Given this list of marker genes NPC1, RNF41, LZTS1, SCFD1, VPS13C (NCBI Gene Id 57581), HMOX1, QSOX1, USP30, FBXL4, NRBP2, PPTC7, UBQLN4, CLEC16A, NUPR1, AKT1, LYPLA1, TP53, TMEM39A, BECN1, EHMT2, LRRK2, RUBCN, MTOR, POLDIP2, SEC22B, TSPO, SMCR8, FEZ2, PIK3CA, PHF23, FEZ1, TSC1, TSC2, HTRA2, RBX1, USP36, MTM1, HDAC6, TIGAR, PINK1, here is a description of the gene set: studied in species Homo sapiens Any process that stops, prevents, or reduces the frequency, rate or extent of macroautophagy. Human Gene Set: GOBP_NEGATIVE_REGULATION_OF_MACROAUTOPHAGY